Given this list of marker genes DERL1, UGGT2, OS9, SYVN1, MAN1B1, SEL1L, RNF103, EDEM2, UBC, CALR, RNF5, RNF139, RAD23B, NGLY1, EDEM1, UBA52, UGGT1, MOGS, PSMC1, GANAB, MARCHF6, UBXN1, EDEM3, CANX, AMFR, ENGASE, PDIA3, DERL2, RNF185, RPS27A, VCP, UBB, TRIM13, MLEC, PRKCSH, here is a description of the gene set: N-glycan trimming in the ER and Calnexin/Calreticulin cycle Human Gene Set: REACTOME_N_GLYCAN_TRIMMING_IN_THE_ER_AND_CALNEXIN_CALRETICULIN_CYCLE studied in species Homo sapiens